The following is a description of a gene set: Human Gene Set: HP_OVERLAPPING_FINGERS Overlapping fingers A finger resting on the dorsal surface of an adjacent digit when the hand is at rest. species: Homo sapiens, and this is the list of marker genes: MYH3, COG7, MECOM, PTF1A, EVC, SETBP1, PI4KA, FLNA, SAMD9, TNNI2, TPM2, MYOD1, MADD, PLOD3, BLTP1, MED25, TNNT3, CHST11, DOK7, CNTN1, MOGS, MYBPC1, OTUD5, CTU2 (NCBI Gene Id 348180), PPP1R21, ALG12, COASY, TMEM94, ATN1, BICD2, EBP, NEK9, NALCN, EVC2, PRKDC, FILIP1